The following is a description of a gene set: Human Gene Set: GOBP_EMBRYO_DEVELOPMENT_ENDING_IN_BIRTH_OR_EGG_HATCHING The process whose specific outcome is the progression of an embryo over time, from zygote formation until the end of the embryonic life stage. The end of the embryonic life stage is organism-specific and may be somewhat arbitrary; for mammals it is usually considered to be birth, for insects the hatching of the first instar larva from the eggshell. species: Homo sapiens, and this is the list of marker genes: IFT140, BCOR, ELF5, RARA, IL10 (NCBI Gene Id 3586), PCDH12, HOXB6, ADCY9, EIF2S2, MSGN1, PSMC4, SOCS3, ARNT2 (aryl hydrocarbon receptor nuclear translocator 2), SRSF1, GATA3, CDKN1A, HES5, SLC39A1, NODAL, MAFF (NCBI Gene Id 23764), DLL3, HES7, MYB, STMN3, TBX18, TRAF6, MED12, MBD3, RGMA (NCBI Gene Id 56963), NKX2-6, LLGL2, RXRB, SMIM14, HEY2, MTHFR (methylenetetrahydrofolate reductase), CELF1, YBX3, BIRC6, PLCD3, CHRD, DNAAF2, TCOF1, INPP5B, SOX9, GSC, TIE1, ETV2, HORMAD1, TRAF3IP1, MYO1E, FOXI1, ATF2, KRT8, FKRP, TTPA, CRIPTO, STOX2, MYH6 (myosin heavy chain 6), CDKN1C, PLXNB2, HM13, SEBOX, ABL1, DLL1, SATB2, SLC30A1, KLF4, PKD2, TGFB2, MATR3, NCKAP1, RBPJ, ESRRB, ZBED6, KDM4C, NKX3-1, WDTC1, VPS54, ADAM10, EGFR, WNT2, HOXA9, TFAP2A, PROX1, TWIST1, PTK7, BMP2, CCN1, KDM8, LATS1, EIF4A3, RPA1 (NCBI Gene Id 6117), RBBP6, HOXC6 (NCBI Gene Id 3223), TBL1XR1, PCDH8, SHOX2, HOXC5, GNA13, BCL2L1, STK3, SEC24C, SP3, WNT8A, ST14, ARL13B, GSE1 (Gse1 coiled-coil protein), TBX2, FGF2, LUZP1, SLC39A3, AXIN2, FKBP8, TMEM107, NOTCH2, ELL, NKD1, PSMC3, FXN (NCBI Gene Id 2395), SCEL (NCBI Gene Id 8796), WNT7B, RRM2 (ribonucleotide reductase regulatory subunit M2), JUNB, TLE6, CTHRC1, ACSL4, TRIM71, HOXB7, EYA1, CAPN2 (calpain 2), TAPT1, LIF, TBX15, STK4, CHD7, CNOT1, RTN4 (reticulon 4, NCBI Gene Id 57142), HCFC1, GRHL3, VANGL2, PHGDH, GRB2, EGLN1, ADA, MESP1, PRDM1, NPAT, DAD1, SALL4, MDFI, BCL2L11, DBN1, MEGF8, NOG, PTPRR, ZPR1, SCRIB, TGFB1, SH3PXD2A, TMEM100, EPN1, IGF1, EPAS1, PDGFB, KAT2A, MED1, MGAT1, HOXB3, GPI, GNA12, ABI1, DSCAML1, SIX4, UBTFL1, DNAJB6, ITPK1, PADI6, FERD3L, ALX3, SEMA4C, SOX18, POLR1B, CC2D2A, CEBPA, GJB5, GDF1, ZIC3, LPAR6, TP53, APBA2, TGFBR2, BYSL, PCDHA10, RBM46 (NCBI Gene Id 166863), FBXW8, PAX6, SPECC1, FKBP10, CDK20 (NCBI Gene Id 23552), SCX, TGIF1, GATA6 (GATA binding protein 6), MAF, RIPPLY1, EOMES, ERCC2, OVOL2, XYLT1, MYO18B, WDPCP, ACVRL1, FBLL1 (fibrillarin like 1), SKI, KLHL12, HOXB1, AGBL4, SPECC1L, SULF2, DZIP1L, MAPK1, SIX2, MIB1, MYF6 (NCBI Gene Id 4618), RSPO3, CITED2, NDUFA2, RCN1, PEMT, EN1, IHH, FOXA1, GATA1, HOXA2, SMAD4, AR, SPINT1, HIF1A, MTHFD1L, SF3B6, PAX7, TTLL4 (NCBI Gene Id 9654), MYF5, STIL, MYCN, PAX2, HOXB5, RIC8A, ACVR1B, DLG1, SDC4, NBN, BMP5, DMRT2, ADGRF5, HOXA11, IRX5, GINS1, BTF3, LFNG, BPTF, POLG2, BNIP2, IFT172, GLI3, DVL1, HEY1, MFNG (MFNG O-fucosylpeptide 3-beta-N-acetylglucosaminyltransferase), RUNX2, BAP1, CUL4A, GPR161, GLMN, DLC1, EVX1, VASH2, EP300, KIDINS220, CTR9, IWS1, ZFP36L1, CTNNB1, EPHA2, ALKBH1, PLPP4, HES1, OPA1, HOXD10, ACVR1C, HDAC3, SOX8 (NCBI Gene Id 30812), NEK2, GATA2, MBTD1, IFT122, N4BP2L2, RPL13, PRPF19, CRB2, AKT1, DLX1 (NCBI Gene Id 1745), BBS4, SEC24B, TMED2, NRARP (NOTCH regulated ankyrin repeat protein), MTHFD1, PHACTR4, DLX2, SIX1, PTCH1, GABPA, ARHGDIG, ASF1B (NCBI Gene Id 55723), PLOD3 (NCBI Gene Id 8985), MFRP, WNT1, ENDOG, UBR3, ARNT, CDX1, RAD51B, BCL10, FOSL1, IFT52, AKAP3, DEAF1, HUS1, SEMA3C, CITED1, FOXC2, EMX1, ZFAND5, FLVCR1 (NCBI Gene Id 559), UPB1, ANKS6, HOXA5, VASH1, RPS7, LIG4, NKX3-2, MARCKS, PDGFRA, HYAL1, OTUD7B, ITGB1, IGF2, SPIC, MAFG, GDF7, FOLR1, HOXD3, FGF8, MOSMO, HOXC11, NSRP1, YBX1, CCM2, COL11A1, TENT5C, UNK, ARHGAP35, RTF1, ZNF358, PTPN18, TCF15, ZNF568, RICTOR, LRP2, DCHS1, ADAMTS3, SOX15, COL2A1, PEF1, MSH2, TET1, SUV39H1, HOXB8, SLC39A12, ETNK2, NECAB1, HEG1, FOXF1, CDX4 (caudal type homeobox 4), POGLUT1, AMBRA1, TAB1, SULF1, CASP8, WNT3A, DLX4, KRT19, FOXC1, SMAD2, EXT1, APOB, LRP6 (LDL receptor related protein 6), PSEN1, PHF6, LATS2, ZFP14, CMIP, TBX1, YTHDC1, SLC35E2B, CAMSAP3, RDH10, PBX1, FLCN, CSF2, NOTCH1, MT-ND4, WNT5A, E2F8, SLC34A2, BMPR1A, NUP50, CCNB2, XAB2, TCTN1, PRKDC, KIFBP, ADM, SIN3A, INTS1, RRN3, CENPU, MKS1, HSD17B2, OSR2, THOC2, PSPH, WDR74, DLX6, BMP7, KLF2, ALDH1A2, FOXD3 (forkhead box D3), EDN1, CIR1, HS6ST1, TEAD4, C1orf43, SHH, COPS2, SYF2, KBTBD8, PPP4R4, TMEM231, C2CD3, TSC1, APBA1, MAP2K1, GGNBP2, CHD8, RPL7L1, INPP5K (NCBI Gene Id 51763), RBBP8 (RB binding protein 8, endonuclease), UPF3A, PLG, MMP16, PITX2, BRCA2, PNLDC1, HOXD9, NR2F2, DYNC2I1, DKK1, BMI1, MFN2, CASP3, SPINT2, PRRX1, PRKACA, MEOX2, COL3A1, ISL1, ALX1, GINS4, SLC35D1, CMTM3, PLXNA2, SCO2, ECE1, EMP2, TULP3 (TUB like protein 3), ZEB2, HSD17B7, NIPBL, MED21, PLK4, PELO, CELF4, SEC24D, COBL, HOXD11, CNOT3, PDCD6, FZD6, FGF9, EDNRA, DLX3, PALB2, HOXA7, NCOA1, MMP14, LHX2, RALA, POLB, INTU, SKIL, EGFL8, CCDC62, DHX35, FGFR2, TERF2, FURIN, RPGRIP1L, CECR2, TBC1D32, POFUT1, TRIM28, WNT9A (NCBI Gene Id 92832), JAG2, LIAS, HOXD4, TRIP6, TFEB, FZD5, SSBP3, GRN, MSX1, SFRP2, CELSR1, EMG1, PAX1, CCNB1, XRCC2, WDR83, MXI1, AMOT, SMAD3, GDF3, PRDM14, SLC25A20, BMPR2, TBXT, IFITM5, KPNA7, HOXA4, ZEB1, SOX17, COPS3, WDR19, HSF1, SBDS, NXN, MYH10, KAT5, TBX6, ZMIZ1, HINFP, RTCB, NKX2-5, E2F7, MYBPHL, ALX4, FUZ, IFT57, ATM, ZFPM2, CFL1, ZNF335, AKIRIN2 (NCBI Gene Id 55122), MEOX1 (mesenchyme homeobox 1), SMO, HOXB4, FOXI3, TEAD2, NOLC1, LEF1, SUFU, MESP2, ZNF830, TGFBR1, GLI2, SENP2, APBA3, RUNDC1, PHLDA2, PCGF2, SOX11, CPT2, CLUAP1, CBY1, AXIN1, VEGFA, ACVR2A, PCSK5, POU5F1, HOPX, HAND2, NSUN2, BMP4, NDEL1, FZD3, FGFR1, TAF8, YAP1, NMT1, TAF10, HS3ST6, SNAI1, PRKACB, ACVR1, CUL3, PKD1, PPP2R3A, HOXB2, DSC3, NLE1, SSR2, PRMT1, GBX2, DIAPH3, ACTL6A, ELF3, RIPPLY2, DACT1, PAX5, RIPPLY3, BRK1, BRCA1, ATP6AP2, DVL2, NOS3, KIF20B, HOXD1, TTLL1, HOXC9, HOXA1, C6, CCNB1IP1, PFN1, TBX3, OCRL, HOXA6, LHX1, ZP3, CHEK1, CCDC24, KIAA1217, MBNL1 (NCBI Gene Id 9850), TCAP, GRHL2, NF1, NPM2, SLC5A7, FOXB1, HNF1B, CERT1, TFAP2C, APAF1, CNOT2, ASCL2, ARMC5, NCAPG2, SMG9, SOX10, SUPT6H, PTH1R, MYH9, BRD2, TTBK2, SRF, HOXB9, SLC25A34, LMO4, KDM2B, ANGPT1, UCMA, RNASEH2B, CHST11, TM4SF1, KEAP1, FUT8, CHTOP, ST8SIA6, MAN2A1, TGFB3, HOXC4, CTCF, SMARCB1, SLC2A10, CEBPB, RNF220, RAI2, HAND1, PRICKLE1, VASP, CDX2, GCM1, USP22, PPP1CC, RRP7A, TSC2, WNT11, RARG, SFRP1, UBE2B, HOXA3, MAFB, NR5A2, NDST1, WNT9B, NSDHL, NASP, OSR1, B9D1, RBP4, DLX5 (distal-less homeobox 5), COL1A1, NUP133, EPB41L5